Given this list of marker genes ERF (ETS2 repressor factor), HBEGF, PPP1R1A, MTCL2, CBX6, SLC35C2, MLXIP, GIT2, SPNS2, MLST8, RAB1B, JAKMIP3, APOL6, STK40, FSTL4, MPP2, CD151, VAT1, G6PD, PIRT, NECTIN1, STAG1, TEAD3, UNC5A, CACFD1, CST9, SDK2, LHPP, ASB6, MYEOV, GTDC1, ANGEL1, TIFAB, TOB2, FA2H, NAA60, SPRN, CD276, CPEB2, ATG16L1, CCND3, ADGRA2, NPTXR, LRP4, CHPF, PCBP3, CRAT, ITM2C, PHB1, ALS2CL, NALF2, CHD5, TMCC1, NSMF, CDR2L, MAGT1, SYNDIG1L, SMARCD1, FOXN2 (forkhead box N2), ATRN, VASP, SLC6A9, SDC3, PBX1 (NCBI Gene Id 5087), TPTE, SARM1, UBE2Z, SUSD6, USP4, CELF5, GALNT2, VANGL2, PLPPR2 (NCBI Gene Id 64748), TMEM229B, SEPTIN9, NIPSNAP1, CASC3, ZFYVE27, CIT, MRAP2, CYP26B1, NAT8L, TSPAN9, SLC7A8, MAP1B, POU2F2, DISP2, ABHD4, CCDC102A, CCL22, IL6ST, ARC, NFASC, TP53I11, NHERF2, KRTAP4-5, CRTC1, MAPKAPK2, MTA3, THEM5, MARK2, TRIM67, ADAMTS10, BCL7B, MAFK, PPP3R1, CACNA2D1, NBPF1, UNC13D, ISM2, RLN3, DOLPP1, TUBB6, PEF1, ZNF740, UNK, FBXO41, CACNB3 (calcium voltage-gated channel auxiliary subunit beta 3), RARA, ANKRD63, VAMP1, RCVRN, GPR137, TMEM201, CDK5R1, WNT7B, LSM12, MAPK8IP3, KDM4B, ABCC5, KSR2, LRP1, TLN1, ETF1, SCN2B, CLASP1, WDTC1, CNTN2 (contactin 2), MNT, GRM4, TAF12, TTC5, RNF216, CSRP1, DCUN1D3, ADAMTS16, GOLGB1, CHAD, PRR15L, HK1 (hexokinase 1), SSH2, VPS11, PACS2, PITPNM2, IPO9, GPSM1, AKAP5, SEMA3F, ZFP41, SLC25A23, CTXN1, RXRA, LDLRAD2, ATP11A, BARHL2, LENG8, WBP1L, SIX5, SDC1, SLC7A1, SH3KBP1, CASTOR2, C2orf72, RASL10B, SLC13A5, MON1B, POLR1G, FAM120C (NCBI Gene Id 54954), JADE2, TFE3, AFAP1L1, SLC22A11, CDC42BPB, TCAF2, NDRG1, SLC22A8, NR6A1, PDGFRB, SLC35E4, PLXNA1, DCHS1, DAGLA, MECP2, DEF8, PIK3CG, ATXN7L3, ORAI2, HYAL2, CHAC1, CAPN7, MAFG, CBX5, NFIC, ZMYM3, TMA7, CNIH2, DDX3X, NAV3, CHRNA6, ZNF285, GNAO1, ABCG4, SH3PXD2B, MEF2C, LYST (lysosomal trafficking regulator), BRPF3, ASXL1, F7, EPHA10, ARRB1, KLF6, GTPBP2, B4GALNT1, GNAI2, STAT6, RBBP5, NGEF (NCBI Gene Id 25791), NACC1, DMBX1, NOS1, ATG9A, NBPF3, RAB43, KIF21B, NATD1, SV2A, TSPAN5, KCNG1, SLC6A17, SLC35E2B, SLC43A2, STIM1, SSR3, NES, LINGO1, PDPK1, GATAD2B (GATA zinc finger domain containing 2B), here is a description of the gene set: Human Gene Set: MIR4763_3P Genes predicted to be targets of miRBase v22 microRNA hsa-miR-4763-3p in miRDB v6.0 with MirTarget v4 prediction scores > 80 (high confidence targets). from publication Chen Y, Wang X (PMID 31504780) studied in species Homo sapiens